The following is a description of a gene set: Decreased activity of mitochondrial complex II species: Homo sapiens A reduction in the activity of the mitochondrial respiratory chain complex II, which is part of the electron transport chain in mitochondria. Human Gene Set: HP_DECREASED_ACTIVITY_OF_MITOCHONDRIAL_COMPLEX_II, and this is the list of marker genes: SDHB, SDHA, IBA57, MECR, BOLA3, SLC39A8, COQ4, TRMT10C, ISCU, FDX2, NFU1, FBXL4, CHCHD10, MIEF2, SDHD, NFS1, UQCC2